Given this list of marker genes CTSD, CLN5, CLN3, PPT1, TARS2, DNAJC5, CLN8, CLN6, TPP1, PSAP, here is a description of the gene set: Increased cerebral lipofuscin species: Homo sapiens Lipofuscin (age pigment) is a brown-yellow, electron-dense, autofluorescent material that accumulates progressively over time in lysosomes of postmitotic cells, such as neurons and cardiac myocytes. This term pertains if there is an increase in the accumulation of lipofuscin (also known as autofluorescent lipoprotein) more than expected for the age of the patient. Human Gene Set: HP_INCREASED_CEREBRAL_LIPOFUSCIN